Given this list of marker genes Gmppb, Gmppa, here is a description of the gene set: studied in species Mus musculus This event has been computationally inferred from an event that has been demonstrated in another species.<p>The inference is based on the homology mapping from PANTHER. Briefly, reactions for which all involved PhysicalEntities (in input, output and catalyst) have a mapped orthologue/paralogue (for complexes at least 75% of components must have a mapping) are inferred to the other species. part of: Synthesis of substrates in N-glycan biosythesis Reactome Pathway: Synthesis of GDP-mannose electronically inferred by orthology from the curated human pathway